The following is a description of a gene set: Mouse Gene Set: GOMF_PHOSPHOLIPASE_C_ACTIVITY species: Mus musculus Catalysis of the reaction: a phospholipid + H2O = 1,2-diacylglycerol + a phosphatidate., and this is the list of marker genes: Plce1, Plcd1, Gdpd5, Plcg2, Plcl1, Ccr1, Plcd3, Plch2, Plcz1, Pdgfra, Plch1, Plcb1, Ccr1l1, Plcb2, Ccl5, Hras, Plcb3, Smpd1, Plcd4, Plcl2, Plcb4, Plcg1